The following is a description of a gene set: Any process that activates or increases the frequency, rate, or extent of interferon-gamma production. Interferon-gamma is also known as type II interferon. species: Homo sapiens Human Gene Set: GOBP_POSITIVE_REGULATION_OF_TYPE_II_INTERFERON_PRODUCTION, and this is the list of marker genes: TLR9 (toll like receptor 9), HSPD1, IL23R, IL12B, PYCARD, IL12A, IRF8, SASH3, TRIM27, APP, TLR4, TLR8, BCL3, TNF, F2RL1, IL18R1, IL12RB1, WNT5A, BTN3A1, HLA-DPA1, IL12RB2, SLAMF1, HAVCR2, SLC7A5, ISL1, LTA (NCBI Gene Id 4049), HMHB1, HMSD, ARID5A, IL27, IL21, CD244, TLR3, IL18, TXK, HLA-A, IL2, SLC11A1, IL27RA, ISG15, CD276, CEBPG, FADD, RIPK2 (receptor interacting serine/threonine kinase 2), HLA-DPB1, IL1B, FZD5, LILRB1, CD160, PTPN22, KLRK1, CCR2, PDE4B, CRTAM, CD226, LGALS9, CD3E, PDE4D, SCRIB, CYRIB, CD2, SLAMF6, ZP3, JAK2, BTN3A2, CLEC7A, IL1R1, ZFPM1, ABL1, CD14, KLRC4-KLRK1, EBI3, IFNL1, HRAS, IL23A, TNFSF4, TYK2, TLR7